The following is a description of a gene set: Genes up-regulated in neutrophil 3d vs 0d in adults after exposure to 2011-2012 trivalent inactivated vaccine (A/California/7/09 (H1N1), A/Perth /16/2009 (H3N2), B/Brisbane/60/2008), time point 3D. Comment: Up-regulated DE RNA transcripts (up >= 1.5x) shared between both TIV-vaccinated donors studied in species Homo sapiens Human Gene Set: HOEK_NEUTROPHIL_2011_2012_TIV_ADULT_3DY_UP Systems biology is an approach to comprehensively study complex interactions within a biological system. Most published systems vaccinology studies have utilized whole blood or peripheral blood mononuclear cells (PBMC) to monitor the immune response after vaccination. Because human blood is comprised of multiple hematopoietic cell types, the potential for masking responses of under-represented cell populations is increased when analyzing whole blood or PBMC. To investigate the contribution of individual cell types to the immune response after vaccination, we established a rapid and efficient method to purify human T and B cells, natural killer (NK) cells, myeloid dendritic cells (mDC), monocytes, and neutrophils from fresh venous blood. Purified cells were fractionated and processed in a single day. RNA-Seq and quantitative shotgun proteomics were performed to determine expression profiles for each cell type prior to and after inactivated seasonal influenza vaccination. Our results show that transcriptomic and proteomic profiles generated from purified immune cells differ significantly from PBMC. Differential expression analysis for each immune cell type also shows unique transcriptomic and proteomic expression profiles as well as changing biological networks at early time points after vaccination. This cell type-specific information provides a more comprehensive approach to monitor vaccine responses. from publication Hoek KL, Samir P, Howard LM, Niu X, Prasad N, Galassie A, Liu Q, Allos TM, Floyd KA, Guo Y, Shyr Y, Levy SE, Joyce S, Edwards KM, Link AJ (PMID 25706537), and this is the list of marker genes: NME4, DDIAS, C12orf60, NAA35, MIR4477A, ZBTB3, GGT5, NXT2, HMGN5, PLAU